Given this list of marker genes Cacna2d1, Sms, Rassf9, Zfp503, Pdgfb, Ppp1r14c, here is a description of the gene set: from publication Chen Y, Wang X (PMID 31504780) Genes predicted to be targets of miRBase v22 microRNA mmu_miR_7040_5p in miRDB v6.0 with MirTarget v4 prediction scores > 80 (high confidence targets). species: Mus musculus Mouse Gene Set: MIR_7040_5P